The following is a description of a gene set: studied in species Homo sapiens Human Gene Set: GOBP_PHOSPHATIDYLCHOLINE_ACYL_CHAIN_REMODELING Remodeling the acyl chains of phosphatidylcholine, through sequential deacylation and re-acylation reactions, to generate phosphatidylcholine containing different types of fatty acid acyl chains., and this is the list of marker genes: PLB1, LPCAT4, NR1H2, PLA2G4C, NR1H3, MBOAT2, LPCAT1, TMEM86B, LPCAT3, PLA2G4B, MBOAT7, LPCAT2, PLA2G2F, DBI, PLA2G4A